The following is a description of a gene set: Human Gene Set: KEGG_MEDICUS_REFERENCE_ANTIGEN_PROCESSING_AND_PRESENTATION_BY_MHC_CLASS_I_MOLECULES Antigen processing and presentation by MHC class I molecules. Pathway ID: N00363. Pathway type: Reference. Pathway class: nt06229 MHC presentation. Pathway Definition from KEGG: TAP1/2 == TAPBP == (PDIA3+CALR) -> (MHCI+B2M) species: Homo sapiens, and this is the list of marker genes: HLA-B, CALR, PDIA3, TAP1, TAP2, HLA-C, HLA-F, HLA-G, HLA-E, HLA-A, B2M, TAPBP